The following is a description of a gene set: The process in which a purine-containing compound is transported across a membrane. A purine-containing compound is any compound that contains purine or a formal derivative thereof. studied in species Mus musculus Mouse Gene Set: GOBP_PURINE_CONTAINING_COMPOUND_TRANSMEMBRANE_TRANSPORT, and this is the list of marker genes: Slc25a16, Slc28a2b, Slc25a41, Slc28a1, Slc28a2, Slc28a3, Slc25a24, Slc25a26, Adcy10, Slc29a1, Aqp9, Slc43a3, Lrrc8d, Slc29a2, Slc35b3, Lrrc8e, Slc33a1, Abcc4, Slc46a2, Slc25a5, Slc25a31, Slc25a47, Slc17a9, Slc35b2, Slc19a1, Slc25a42, Slc25a17, Slc25a23 (solute carrier family 25 (mitochondrial carrier; phosphate carrier), member 23), Lrrc8a, Lrrc8b, Shoc2, Lrrc8c, Slc25a51, Slc29a3, Slc25a4